Given this list of marker genes Atp5if1, Gsk3a, Zfp13, Hip1r, Bak1, Siva1, Chchd10, Bok, Gsk3b, here is a description of the gene set: Mouse Gene Set: GOBP_POSITIVE_REGULATION_OF_MITOCHONDRIAL_OUTER_MEMBRANE_PERMEABILIZATION_INVOLVED_IN_APOPTOTIC_SIGNALING_PATHWAY studied in species Mus musculus Any process that activates or increases the frequency, rate or extent of mitochondrial outer membrane permeabilization involved in apoptotic signaling pathway.